The following is a description of a gene set: Genes predicted to be targets of miRBase v22 microRNA mmu_miR_196b_3p in miRDB v6.0 with MirTarget v4 prediction scores > 80 (high confidence targets). from publication Chen Y, Wang X (PMID 31504780) species: Mus musculus Mouse Gene Set: MIR_196B_3P, and this is the list of marker genes: Gpr146, Smg7, Irf3, Ppargc1b, Plscr4, Tmem128